Given this list of marker genes GPATCH1, ISG20, PEX5, GP6, GAN, ANXA9, ITGB3, ZMYM5, COL7A1, KMT2A, ZBED4, RCAN1, BCL11A, MTUS1, UNC5B, MAF, IDI2-AS1, B4GALT4, KAZN, ITGA10, AGT, TNIK (NCBI Gene Id 23043), CCND1, OTUD4 (OTU deubiquitinase 4), LILRA1, GATA1, AGFG2, SRPK3, SLC1A2, DST, JRKL, HDAC6, TMEM187, CACYBP, EXO5, ZC3H7B, ITGB4, TSPAN9, SUCLG1, BPHL, UBR4, NF1, PDLIM5, IRF6, HJURP, SALL2, KEL, IL36A, AMELX, PRLH, NECTIN1, CLDN18, CEP76, PIK3IP1, FOXO3, GLRA2, SENP6, BIN1, MAPK7, TSPAN5, N4BP1, TOP3B, HADHAP1, AKR1C1, YWHAH-AS1, ATP5MC2P1, ZFP36L1, PPP1R9A, DLG3, RBPMS, TMEM140, VEGFB, MED20, CDC37L1, IGF1R, SLC9A5, MFSD6, GEMIN6, DCAKD, LPP, NTRK3, TRIM23, MAB21L2, MSR1, COL6A1, SERPINB4, DBT, CMKLR2 (chemerin chemokine-like receptor 2), HCFC1, DCAF4, PEX1, LINC00390, PPP1R3D, MYO10, STAM2, MMP11, CYP2R1, GRIK5, MID2, NF2 (NCBI Gene Id 654093), LAMB2, WDFY3, METTL2B, KBTBD4, OR2B6, ZNF639, SLIT2, ETS1, CPT2, EVPL (NCBI Gene Id 2125), LGALSL, ABLIM1, INO80B, ITFG2, TRIM33, ZCCHC4, CDK14, MPHOSPH9, ALS2CL, RNASEH2B, SMAD6, FBXO9, PIK3C3 (NCBI Gene Id 5289), ARIH2, GJA9, TMPRSS11D, CFHR2, MYCNOS, GPR4, JAG2 (jagged canonical Notch ligand 2), here is a description of the gene set: Tumors contain a fraction of cancer stem cells that maintain the propagation of the disease. The CD34(+)CD38(-) cells, isolated from acute myeloid leukemia (AML), were shown to be enriched leukemic stem cells (LSC). We isolated the CD34(+)CD38(-) cell fraction from AML and compared their gene expression profiles to the CD34(+)CD38(+) cell fraction, using microarrays. We found genes that were at least twofold over- or underexpressed between the two cell populations. These include underexpression of DNA repair, signal transduction and cell cycle genes, consistent with the relative quiescence of stem cells, and chromosomal aberrations and mutations of leukemic cells. Comparison of the LSC expression data to that of normal hematopoietic stem cells (HSC) revealed that 34% of the modulated genes are shared by both LSC and HSC, supporting the suggestion that the LSC originated within the HSC progenitors. We focused on the Notch pathway since Jagged-2, a Notch ligand was found to be overexpressed in the LSC samples. We show that DAPT, an inhibitor of gamma-secretase, a protease that is involved in Jagged and Notch signaling, inhibits LSC growth in colony formation assays. Identification of additional genes that regulate LSC self-renewal may provide new targets for therapy. Genes up-regulated in leukemic stem cells (LSC), defined as CD34+CD38- cells from AML (acute myeloid leukemia patients) compared to the CD34+CD38+ cells. studied in species Homo sapiens Human Gene Set: GAL_LEUKEMIC_STEM_CELL_UP from publication Gal H, Amariglio N, Trakhtenbrot L, Jacob-Hirsh J, Margalit O, Avigdor A, Nagler A, Tavor S, Ein-Dor L, Lapidot T, Domany E, Rechavi G, Givol D (PMID 17039238)